Given this list of marker genes NUP155, LMNB2, TMEM201, OSBPL8, NUTF2, LMNB1, INTS13, TOR1AIP2, SUMO1, NUP54, TMEM147, PLK1, LMNA, TOR1AIP1, here is a description of the gene set: Human Gene Set: GOBP_PROTEIN_LOCALIZATION_TO_NUCLEAR_ENVELOPE studied in species Homo sapiens A process in which a protein is transported to, or maintained at, a location within a nuclear envelope.